Given this list of marker genes VTN, APOH, THBS2, NCAN, FN1, APP (NCBI Gene Id 351), PTN, THBS4, APOE, MDK, CCL8, TGFBR3, PRG2, FSTL1, FGFBP1, CXCL6, HRG, FGFR1, HBEGF, CCL7, AOC1, LPL, FGF9, CCL23, LIPC, SERPIND1, APOB, LAMC2, here is a description of the gene set: Heparin binding. Human Gene Set: MODULE_385 studied in species Homo sapiens